Given this list of marker genes GRIK3, DEPP1, RPE (ribulose-5-phosphate-3-epimerase), ACOX1, ZBTB24, AGGF1, CDKN3, CFLAR, FBXL2, OFD1, AJAP1, ZNF24, TSPYL5, FRY, RNF216P1, ARL4C, PHF20 (NCBI Gene Id 80330), BICD1, S100A3, MTF2, ZNF230, TBC1D31, PMS2 (PMS1 homolog 2, mismatch repair system component), ORC2, KDM6A, SMAD5, ATPAF2, ZNF44, ELF2, MDC1, DUSP10, MTM1, COIL, CLCN6, BACH1, CDC23, TTC9, ITGAE, PRKAR2B, MEIS1, HOXA11, DSP, YLPM1, STAU2, TSPYL4, LINC01565, NCK1, RIN1, CBLB, PARP4, PPP2R1B, TLE4, SLC22A4, ARNT2, PEX7, CSTF2T, MN1, OSR2, TCF21, RGS19, FGF2, CDKN1B, ID2, FBXL5, PRR3, DOP1A, ETV1, TSC22D2, PHF3, SMAD3, NAP1L3, FAM168A, GPRC5A, PEX11B, LRIG2, BICRAL, ALMS1, NORAD, ARID5B, PNISR, THBD, MDM2, CASP6, STON1, SCAF8, RPP14, P2RY10, HDAC9, MDM1, RO60, HOXA10, F2RL1, EPB41, ICA1, MTAP, TRIM2, PSG3, GLI2, MED21, SMAD1, AMOTL2, DUSP6, KIN, ZNF623, GOSR2, HOXC6, NTF3, TXNIP, IL7, TGIF1, BRD1, TDRD3, ANKRD28, PCMTD2, CEP112 (centrosomal protein 112), ADCY7, KANK1, HMGA2, PRDM2, BCL9, MNT, ZNF175, SGK1, ADORA2B, THOC2, MSX2, NR3C1, RNF113A, ZNF8, SRGAP2, BHLHE40, FPGT, GRM8 (glutamate metabotropic receptor 8), GIMAP5, PLCB4, RND3, TTF1, GLB1L2, DFFA, ITGA6, DMTF1, CENPF, FADD, CDS2, S1PR1, CDC40, GSAP, CREB5, WEE1, CEP68, SCHIP1, GTF2H2, ARHGEF2, GAS1, LAMC2, GAS2, TJP2, ITGB3, BDKRB2, TCF7L2, GLOD4, DKK1, TBC1D8, PIK3R1, here is a description of the gene set: Genes down-regulated in primary fibroblast cell culture point after infection with HCMV (AD169 strain) at 6 h time point that were not down-regulated at the previous time point, 4 h. Human Gene Set: BROWNE_HCMV_INFECTION_6HR_DN species: Homo sapiens The effect of human cytomegalovirus (HCMV) infection on cellular mRNA accumulation was analyzed by gene chip technology. During a 48-h time course after infection of human diploid fibroblasts, 1,425 cellular mRNAs were found to be up-regulated or down-regulated by threefold or greater in at least two consecutive time points. Several classes of genes were prominently affected, including interferon response genes, cell cycle regulators, apoptosis regulators, inflammatory pathway genes, and immune regulators. The number of mRNAs that were up-regulated or down-regulated were roughly equal over the complete time course. However, for the first 8 h after infection, the number of up-regulated mRNAs was significantly less than the number of down-regulated mRNAs. By analyzing the mRNA expression profile of cells infected in the presence of cycloheximide, it was found that a minimum of 25 mRNAs were modulated by HCMV in the absence of protein synthesis. These included mRNAs encoded by a small number of interferon-responsive genes, as well as beta interferon itself. Cellular mRNA levels in cytomegalovirus-infected cells were compared to the levels in cells infected with UV-inactivated virus. The inactivated virus caused the up-regulation of a much greater number of mRNAs, many of which encoded proteins with antiviral roles, such as interferon-responsive genes and proinflammatory cytokines. These data argue that one or more newly synthesized viral gene products block the induction of antiviral pathways that are triggered by HCMV binding and entry. from publication Browne EP, Wing B, Coleman D, Shenk T (PMID 11711622)